The following is a description of a gene set: Human Gene Set: GOMF_PROTEIN_LIPID_COMPLEX_BINDING species: Homo sapiens Binding to a protein-lipid complex, any macromolecular complex that contains both protein and lipid molecules., and this is the list of marker genes: IHH, MSR1, STAB2, ABCA1, APOA1, STAB1, SAMD1, VLDLR, CRP, LPL, LDLR, COLEC12, TREM2, APOA2, APOE, MIR30C1, APOL5, LIPC, GPIHBP1, LRP8, MAPT, PCSK9, MIR9-1, HSPD1, PLTP, APOL2, CDH13, SCARB1, CD36, SORL1, THBS1, SCARF1